The following is a description of a gene set: from publication Bedogni F, Hevner RF (PMID 34321999) Genes expressed at higher levels in caudal regions beginning in the intermediate zone, in some cases extending into the cortical plate of embryonic day 14.5 mouse cortex. Mouse Gene Set: HEVNER_CORTEX_CAUDAL_INTERMEDIATE_ZONE species: Mus musculus, and this is the list of marker genes: Chst15, Robo3, Flrt1, Onecut2, Bhlhe22, Osbpl5, Bcl11a, Lmo1, Cog1